The following is a description of a gene set: studied in species Mus musculus The process in which voltage-gated ion channels become localized to distinct subcellular domains in the neuron. Specific targeting, clustering, and maintenance of these channels in their respective domains are essential to achieve high conduction velocities of action potential propagation. Mouse Gene Set: GOBP_NEURONAL_ION_CHANNEL_CLUSTERING, and this is the list of marker genes: Nfasc, Kcnip2, Cntn2, Sptbn4, Dlg2, Kcnb1, Ank3, Pmp22, Akap5, Sclt1, Cntnap2, Myoc (NCBI Gene Id 98481), Nrcam, Gldn